Given this list of marker genes FGFR2, RAB23, TRPV4, NOG, EOGT, FGFR3, ERF, FIG4, HOXD13, FGFR1, VAC14, IHH, here is a description of the gene set: Human Gene Set: HP_ABNORMALITY_OF_THE_MIDDLE_PHALANGES_OF_THE_TOES studied in species Homo sapiens Abnormality of the middle phalanges of the toes